Given this list of marker genes MITF, RPUSD3, NPB, ZKSCAN5, APOC4, ADGRD1, DHX40, PDP2, FURIN, PTGIS, MST1, NTN4, ATP5MC1, ARHGAP29, EFCAB10 (NCBI Gene Id 100134776), ATP13A3, RNPEP, SORL1, CFAP184, DNAJC15, THOC5, RAB9A, PNMA3, CRTAM, PLEKHA5, CSNK2A2, MAN2B2 (NCBI Gene Id 23324), DDX19A, MIR218-1, RPS27A, TFIP11, RPS15, EARS2, CFAP100, BHLHA9 (basic helix-loop-helix family member a9), VAV1, ULK2, E2F4, CWC25, RNF144A, AK3, GPS2, SIN3A, ATG2A, IL3, MAPKAP1, UAP1, RPS8, ARL10, PIK3R4, ARF6, CYBB, UTP3, GABRA6, MIR99A, RAP1A, GSPT1, ANKRD61, RNF185, CWC15 (NCBI Gene Id 51503), FAM124A, RPAP2, MEGF6, GZMM, FOXK2, RUFY2, FASTKD1, GNS, VPS53, EHBP1L1, SLC30A8, TAX1BP1, REPS1 (RALBP1 associated Eps domain containing 1), SASH3, FAF2, NAF1, ACTR6, SUCLA2, LPAR6, CCZ1, NDUFS5, CLCN2 (NCBI Gene Id 79179), UBQLN1, PARD6B, SPACA3, KRTAP26-1, MEA1, LACTBL1, ATXN7L2, SCLY, EIF3C, ZMIZ2, MALT1, CDKL3, TBX6, NFE2, POU2AF1, OS9, FMNL1, RNF25, SRP72, RPL37, MOB4, FBXL14, RPL13, FCGR3A, NOP53, EFCAB9, EML1 (NCBI Gene Id 2009), POLR1D, USP8, CDK5RAP2, CD68, MYO6, OXSR1, CD86, MRPL20, NUP50, RBSN, IL2RG, IFITM3, MPZL1, TMEM126A, RILPL2, CRTC3, PHLDA1, RPL37A, TTLL5, RASGRF1 (Ras protein specific guanine nucleotide releasing factor 1), EIF4EBP2, ADAM8, OGFOD2, GPBP1L1, CSTF2T, PCNX1, AXIN2, CCL5, ZSWIM4, BICRAL, TRAF3, FBXO28, MYOM1, TIMM9, GTF2E1 (NCBI Gene Id 2960), ALDH1B1, STX8, ZFP64, HOXC10, ZBTB46, FOXL2, SLC4A11, FAM114A2, MAP4K3, PAQR5, GATAD2B, LIPE, CLCA4, RPL41, here is a description of the gene set: from publication Cisse B, Caton ML, Lehner M, Maeda T, Scheu S, Locksley R, Holmberg D, Zweier C, den Hollander NS, Kant SG, Holter W, Rauch A, Zhuang Y, Reizis B (PMID 18854153) Human Gene Set: GSE12505_WT_VS_E2_2_HET_PDC_DN Analysis of expression profiles of pDCs from wild type and heterozygous E2-2 mice. Results show the control by E2-2 of the expression of pDC-enriched genes. studied in species Homo sapiens Genes down-regulated in plasmacytoid dendritic cells: wildtype versus TCF4 heterozygous knockout.